The following is a description of a gene set: species: Mus musculus The chemical reactions and pathways involving a nucleobase, a nitrogenous base that is a constituent of a nucleic acid, e.g. the purines: adenine, guanine, hypoxanthine, xanthine and the pyrimidines: cytosine, uracil, thymine. Mouse Gene Set: GOBP_NUCLEOBASE_METABOLIC_PROCESS, and this is the list of marker genes: Prps1, Gmpr, Shmt1, Hprt1, Adk, Cps1, Uox, Cmpk1 (NCBI Gene Id 66588), Mtor (NCBI Gene Id 80612), Aldh6a1 (aldehyde dehydrogenase family 6, subfamily A1), Cad, Xdh, Tet2, Ctps2, Paics, Aprt, Umps, Urad, Ada, Kdm1a, Ctps1, Dpyd, Tyms (NCBI Gene Id 22171), Dpys, Dpysl3, Urah, Tymp (thymidine phosphorylase), Nt5c2 (NCBI Gene Id 76952), Rrm1, Crmp1, Gda, Pnp, Mapk1, Dhodh, Ppat, Gart, Ttr, Gmpr2, Acp3, Dpysl5, Dpysl4, Dpysl2